The following is a description of a gene set: The steps of transport of dietary cobalamins through the digestive tract to the distal ileum, leading to its endocytosis are annotated here. The proteins involved in these processes accommodate cobalamins including cyanocobalamin, methylcobalamin, and adenosylcobalamin.. This broad specificity is indicated by annotating R-cob(III)alamin (RCbl - ) as the cargo in all of these processes. species: Homo sapiens part of: Cobalamin (Cbl, vitamin B12) transport and metabolism Reactome Pathway: Uptake of dietary cobalamins into enterocytes, and this is the list of marker genes: CUBN, CTRB1, LMBRD1, PRSS1, CBLIF, TCN1, ABCD4, PRSS3, CTRB2, AMN